Given this list of marker genes UBR7, ZNF302, SLC35F2, TFF1, SLC39A8, SGK1, SLC39A14, IER3, CA12, TTC33, CA2, TNFRSF10B, DNAJC11, FRK, STARD7, PHB1, RFC4, MYO19, ATXN3L, ZNF629, GLA, STK26, HSPB8, P2RX5, RBM12B, SNX24, MCM4, SLC16A1, CXCL12, SLK, here is a description of the gene set: Human Gene Set: STEIN_ESRRA_TARGETS_RESPONSIVE_TO_ESTROGEN_UP from publication Stein RA, Chang CY, Kazmin DA, Way J, Schroeder T, Wergin M, Dewhirst MW, McDonnell DP (PMID 18974123) Genes up-regulated by estradiol and up-regulated by ESRRA in MCF-7 cells (breast cancer). Expression of estrogen-related receptor alpha (ERRalpha) has recently been shown to carry negative prognostic significance in breast and ovarian cancers. The specific role of this orphan nuclear receptor in tumor growth and progression, however, is yet to be fully understood. The significant homology between estrogen receptor alpha (ERalpha) and ERRalpha initially suggested that these receptors may have similar transcriptional targets. Using the well-characterized ERalpha-positive MCF-7 breast cancer cell line, we sought to gain a genome-wide picture of ERalpha-ERRalpha cross-talk using an unbiased microarray approach. In addition to generating a host of novel ERRalpha target genes, this study yielded the surprising result that most ERRalpha-regulated genes are unrelated to estrogen signaling. The relatively small number of genes regulated by both ERalpha and ERRalpha led us to expand our study to the more aggressive and less clinically treatable ERalpha-negative class of breast cancers. In this setting, we found that ERRalpha expression is required for the basal level of expression of many known and novel ERRalpha target genes. Introduction of a small interfering RNA directed to ERRalpha into the highly aggressive breast carcinoma MDA-MB-231 cell line dramatically reduced the migratory potential of these cells. Although stable knockdown of ERRalpha expression in MDA-MB-231 cells had no effect on in vitro cell proliferation, a significant reduction of tumor growth rate was observed when these cells were implanted as xenografts. Our results confirm a role for ERRalpha in breast cancer growth and highlight it as a potential therapeutic target for estrogen receptor-negative breast cancer. species: Homo sapiens